Given this list of marker genes CLEC4D, DEFA5, COTL1, ATG5, BAK1, CLEC7A, IL17RA, JAGN1, CLEC4E, SYK, PTX3, HAMP, CRK, TLR4, HTN3, HRG, DEFB106B (defensin beta 106B), IL36RN, DCD, ANG, TRIM62, MPO, DEFB136, FAM3A, USP15, MALT1 (NCBI Gene Id 10892), PLCG2, ADM, DEFA6, NPY, PLA2G5, IL25, DEFA3, SPON2, CX3CR1, LTF, TGFB1, CARD9, POMC, SPI1, VIP, DEFB119, APP, ARG1, LEAP2, ZBP1, RARRES2, DEFB114, DEFA4, CLEC4C, CHGA, ELANE, IL17RC, MYD88, TSLP, S100A12, CLEC6A, HTN1, GPR15LG, CAMP, S100A8, NCF1, S100A9, IL17A, BCL10, DEFB4A, CTSG, NLRP10, RNASE7, BTK, CLEC4A, RNASE8, CALCA, DEFB106A, DEFA1B, TAC1, GNLY, SCIMP, DEFA1 (defensin alpha 1), GAPDH, here is a description of the gene set: Any process that results in a change in state or activity of a cell or an organism (in terms of movement, secretion, enzyme production, gene expression, etc.) as a result of a stimulus from a fungus. Human Gene Set: GOBP_RESPONSE_TO_FUNGUS species: Homo sapiens